Given this list of marker genes TREM2, OCSTAMP, ADAM9, DCSTAMP, TYROBP, here is a description of the gene set: Human Gene Set: GOBP_REGULATION_OF_MACROPHAGE_FUSION Any process that modulates the frequency, rate or extent of macrophage fusion. species: Homo sapiens